Given this list of marker genes EXT2, NMNAT1, EXT1, GLB1 (galactosidase beta 1), GALNS, NAXE, ARSB, COL2A1, here is a description of the gene set: Cervical myelopathy Human Gene Set: HP_CERVICAL_MYELOPATHY A collection of pathologic conditions that result from progressive spinal cord dysfunction secondary to cord compression in the cervical spine. studied in species Homo sapiens